The following is a description of a gene set: We previously identified toll-like receptor 4 (Tlr4) as a candidate gene responsible for ozone (O3)-induced pulmonary hyperpermeability and inflammation. The objective of this study was to determine the mechanism through which TLR4 modulates O3-induced pulmonary responses and to utilize transcriptomics to determine TLR4 effector molecules. C3H/HeJ (HeJ; Tlr4 mutant) and C3H/HeOuJ (OuJ; Tlr4 normal), mice were exposed continuously to 0.3 ppm O3 or filtered air for 6, 24, 48 or 72 hr. Affymetrix Mouse430A_MOE gene arrays were used to analyze lung homogenates from HeJ and OuJ mice followed using a bioinformatic analysis. Inflammation was assessed by bronchoalveolar lavage and molecular analysis by ELISA, immunoblotting, and transcription factor activity. TLR4 signals through both the MYD88-dependent and independent pathways in OuJ mice, which involves MAP kinase activation, NF-kappaB, AP-1, and KC. Microarray analyses identifiedTLR4 responsive genes for strain and time in OuJ versus HeJ mice (p<0.05). One significantly upregulated cluster of genes in OuJ were the heat shock proteins (Hspa1b; Hsp70), Hsp90ab1). Furthermore, O3-induced expression of HSP70 protein was increased in OuJ compared to HeJ mice following 24-48 h O3. Moreover, BAL polymorphonuclear leukocytes (PMN) and total protein were significantly reduced in response to O3 in Hspa1a/Hspa1btm1Dix (Hsp70-/-) compared to Hsp70+/+ mice (p<0.05). TLR4 signaling (MYD88-dependent), ERK1/2, AP-1 activity, and KC protein content were also significantly reduced after O3 exposure in Hsp70-/- compared to Hsp70+/+ mice (p<0.05). These studies suggest that HSP70 is involved in the regulation of O3-induced lung inflammation through the TLR4 pathway and provide evidence that HSP70 is an endogenous in vivo TLR4 ligand. Human Gene Set: GSE20715_0H_VS_6H_OZONE_TLR4_KO_LUNG_DN studied in species Homo sapiens Genes down-regulated in comparison of lung tissue from wild type mice subjected to ozone for 0 h versus that from TLR4 deficient mice subjected to ozone for 6 h. from publication Bauer AK, Rondini EA, Hummel KA, Degraff LM, Walker C, Jedlicka AE, Kleeberger SR (PMID 21543283), and this is the list of marker genes: SLC6A15 (NCBI Gene Id 59276), LRRC49, RAB24, DNAJC21, CAPN15, DDX5, HP, CCDC102A, CDPF1, DOCK5, SLC44A4, HERC2, ENTPD5, ZFYVE21, CYB5A, SHOC2, EPS8L1, GFRA1, OTUD4, LY75, ANKRD13A, NFKBIA, TADA1, FZD5, FZD8, DYNLT4, SP2, ANKRD44, GBGT1, CXCL17 (NCBI Gene Id 284340), ARID4B, CCDC137, IDE, TOMM20, TRIM23, ELL2, MSL1, AFF1, ELL, DUSP18, ACSS1, CCN2, TGFA, DSP, ABCF3, METTL8, PSMD12, SLC23A2, KLF6, LIN7C, PDE12, GPBP1L1, TNK1, RMDN1, MTMR6, SCNN1G, HS3ST1, BMP2, GID4, CEP95, TMEM243 (NCBI Gene Id 79161), TARDBP, SHPRH, CYP4V2, SERPINA3, RIPK4 (receptor interacting serine/threonine kinase 4), NFE2L2, C16orf87, LRRK2, ALDH3A1, ESRP2, VAMP8, OAZ1, PAIP1, MYCBP2, USP20, DCTN3, OXSR1, KCNK1, FLII, NUP160, PRDX6, PVT1, C5orf22, DNAJA4, TSPAN5, FERD3L, F3, UBR2, UBE2D3, CYS1, TIMP4, DMKN, RHPN2, NUP153, DHCR24, UFSP1, TEF, CTSH, GAS1, KCNJ4, PTGIS, USP24, GPNMB, SAR1B, PAQR7, DLD, IGFBP6, H2AC25, CLEC14A, CEBPD, CYTH2, CHD1, ATF6, ABHD17C, THNSL1, TMUB2, MTHFR, ALG2, CD9, EIF4E, GTF2B, ZFAND2A, DYRK1A, RORA, ARL6IP4, VAPA, ADRB2, RAB5A, ELOA, THOC1, CDC73, SUCNR1, PSMD7, ITPRID2, YRDC, HSPB1, SERP1, TMEM216, FLCN, IRX1, BAG1, IL1RAP, INPP5E, CCDC85A, MAPRE2, DHX36, SLC34A2, RAB34, STK39, GSTA3, INMT, TACSTD2, HERPUD1, GPRC5B, RNF13, CROT, VMP1, ZNF131, HAGH, CSN2, CLDN10, LARP6, SBDS, CHPF2, CDK8, VEGFD, GKAP1, OSGIN1, S100A6, MFN1, ZNF521, EPN2, ZYG11B, LBP, AREG, SCRIB, SEMA5A, TSKU, LCN2, HGF, RPS14, HYCC2, STARD7, F2RL1, ZNF280C, EEA1, PTGS2, DESI1, CCL22, PRR14, BAG3, UBE3A, MBNL1, CES1, ASPH, RNF145 (NCBI Gene Id 353159), MSLN, FAM8A1, NR4A1